Given this list of marker genes PNPO, KIF27, PLEKHS1, XK, RPUSD1, KRT36, TMIE, KCNE5, GPR26, USP15, GAS7 (NCBI Gene Id 8522), FTMT, G2E3, HDAC6, CRYBB2, APIP, MAVS (mitochondrial antiviral signaling protein), SLC39A2, CHAD, WWC1, ZFP2, PYM1, ESPN, HES2, SHISAL2B, F13B, VANGL2, MTR, LOXL3, KLF17, ZNF473, SMAD9, TMOD2, HOXC6, FUT2, PCGF1, AGMAT, SAP30, CCHCR1, VSIR, SYNDIG1L, KCNG4, NRG3, VCAN, RB1 (NCBI Gene Id 92728), BTC (NCBI Gene Id 685), UBXN10, SMPD4, CDIN1, OR2S2, SPATA17, GADD45A, MS4A8, OOEP, PANK2, SLC16A6, FLVCR2, ENSA, ARRDC4, USP21, REXO5, IBA57, TUFT1, GPR150, AQP2, TTF2, MSR1, C6orf132, PIGB, PNMA2, DHRS4, IL31RA, SIX5, TCAF1, IRX4, SPPL2B, RNF24, SLC22A14, CTTNBP2, FAM171A1, MDC1, VTN, RFWD3, TREX2 (NCBI Gene Id 11219), PLCD1, PPP1R3C, TPPP, AP1B1, TIMM50, SNRPN, PLEKHA7, PITHD1, NXPH3, CNNM3, MFAP2, SFTPC, CITED4, LYPD6, AK5, SPMIP9, TPRA1, C9, CARS1, FXYD2, KRTAP26-1, VWA3A, LRRC56 (leucine rich repeat containing 56), SPAG16, TMEM92, ST7, ROPN1L, NDC80, SRPX2 (sushi repeat containing protein X-linked 2), GPR182, PLPP5, FAM163B, PTPN20, PARD3, UNC13A, SPACA4, LRRC38, HHIP, PCSK6 (NCBI Gene Id 5046), SLC26A3, SPATA4, EPN3, OGDH, SULT1A1, SEBOX, SCOC, PHLDA2, CDK5R2, IRF7, TM4SF20, HOXA3, ATP4A, ABCB9, HAS1, USP50 (NCBI Gene Id 373509), KCTD15, TTLL9, FAM162B, TMEM59L (transmembrane protein 59 like), ACOX2, UBE2N, EPHB2, DGKH, TMOD4, ALDH1L1, MAP4K5, UBASH3A, JHY, INS, NENF, ARL4A, SPPL3, APOL6, NOXO1, RTL8C, SLC30A9, ZDBF2, NPR1 (natriuretic peptide receptor 1), IL13RA1, PPM1L, ANO3, KIZ, MPP3, B3GNT3, PIK3R3, USP18, SLC48A1, CRTAC1, PAX6, UROC1 (NCBI Gene Id 131669), CIMIP7, TFF3, FADS2, SLC43A3, TMEM132C, CRYGS, MFAP5, OSBPL10, SLC7A9, CXCL14, FAM83F, PLA1A, HR, THEM5, TRIM23, NAV3, IL17RC, CCDC120, FEZF1, MEMO1, MRPL50, FUT10, SPINK4, FARP1, GLRX5, NHSL2, here is a description of the gene set: Human Gene Set: GSE27786_BCELL_VS_ERYTHROBLAST_DN from publication Konuma T, Nakamura S, Miyagi S, Negishi M, Chiba T, Oguro H, Yuan J, Mochizuki-Kashio M, Ichikawa H, Miyoshi H, Vidal M, Iwama A (PMID 21540074) studied in species Homo sapiens Each fraction of mouse hematopoietic cells was purified by cell sorting from bone marrow of 8-week-old C57BL/6 mice, and its gene expression was analyzed. Genes down-regulated in comparison of B cells versus erythroblasts.